The following is a description of a gene set: Human Gene Set: GSE17721_CPG_VS_GARDIQUIMOD_8H_BMDC_DN species: Homo sapiens from publication Amit I, Garber M, Chevrier N, Leite AP, Donner Y, Eisenhaure T, Guttman M, Grenier JK, Li W, Zuk O, Schubert LA, Birditt B, Shay T, Goren A, Zhang X, Smith Z, Deering R, McDonald RC, Cabili M, Bernstein BE, Rinn JL, Meissner A, Root DE, Hacohen N, Regev A (PMID 19729616) mouse primary BMDCs were stimulated with tlr ligands and gene expression changes were profiled on Affymetrix arrays Genes down-regulated in comparison of dendritic cells (DC) stimulated with CpG DNA (TLR9 agonist) at 8 h versus DC cells stimulated with Gardiquimod (TLR7 agonist) at 8 h., and this is the list of marker genes: HHEX, WBP2, SLC1A2, RBM3, TP53INP2, SFXN1, YRDC, TRPS1, FJX1, RGS10, MYMK, ALDH1A2, DDB1, DAPP1, FAM53C, RASA2, NOMO1, ARRB2, CLEC14A, POLR2A, EXTL3, ARHGAP39, ETFDH, TRAF3, LDB2, PRDM1, GLG1, NCOA5, CARMIL1, ATP6V1G2, RASSF3, CTBS, CANX, MRPL3, TBC1D8, UBR5, SLC66A2, EMC6, YES1, PRKD3, IPO8, DICER1, ARPC3, AMPD3, RBM5, PKDCC, POLD4, MAPK3, BOC, IL1RAP, SMC3, JAGN1, RRBP1, PHTF2, LNX2, ADAM19 (ADAM metallopeptidase domain 19), NDRG2, ADAM15, KRT85, SRM, TPK1, KLHL22, ARFGEF1, PTPA, PRRC2A, ESYT1, PABPC4, MOCOS, PCNX4, KCNE2 (NCBI Gene Id 9992), LRP8, BRPF1, RAPGEF4, SLC4A8, TESK2, DLG1, EMC9 (NCBI Gene Id 95655), RDH10, TMX1, RPS16, FGF3, KCTD1, SLC2A1, MED20, HSPA2, BAG3, LHCGR, TNNT1, NDRG4, RPF2, FICD, UTP20, CKLF (NCBI Gene Id 51192), MESD, ATP5F1E, PEX26, SLK, NSUN2, ABT1, ATXN7L1, CH25H, SLC35C1, PRDM4 (PR/SET domain 4), ATP2C2, B3GNT2, ADAM9, PLS3, UBQLN1, USP24, GID4, FOXJ2, SMPDL3B, EEF1G, RASSF5, CYP51A1, HSCB, PBXIP1, PARP9, TXNDC17, RPRD1B, PTRH1, SART3, ZBTB11-AS1, CTDNEP1, HPD, PDCD6IP, TUBGCP3, CBFA2T2, NUDT14, SRP54, WDR6, TMBIM6, NAXE, ARPC1B, TOB2, QKI, ANP32A, EMC7, CXCL3, SERF1A, LSR, METTL18, ZMPSTE24, HEATR1, CCNI, MAPK6, KMT2A, BTBD2, PARP16 (poly(ADP-ribose) polymerase family member 16, NCBI Gene Id 54956), IL17RA, WIPI1, KBTBD2, GLI1, PFKL, SYNE2, EEF1D, DNMT1, CAPN3, F2R, SCAMP1, ADGRE1, ITGB1, KANSL1, KRT12, SMAD6, STAP2, REEP5, ADAM23, ABHD14B, NEK9, WDR13, PAN2, CASR, SORT1, TF, TP53INP1, ACOT13, UTP6, TRAPPC14 (trafficking protein particle complex subunit 14), LTC4S, DNLZ, RPS6KA3, EXT1, RABL6, EIF4ENIF1, TASP1, METAP1, ESPN, IL21R, ZNF318, PLBD1, INTS3, BUD13, CTNNA1, ZDHHC12, SEC63, SCAMP3, TM9SF2, TFRC, ATP6V0B